The following is a description of a gene set: species: Homo sapiens p38MAPK events Human Gene Set: REACTOME_P38MAPK_EVENTS, and this is the list of marker genes: HRAS, RALGDS, MAPK12, KRAS, NRAS, MAPK14, RALB, MAPK13, RALA (NCBI Gene Id 5898), MAPKAPK3, MAPKAPK2, MAPK11, SRC